The following is a description of a gene set: studied in species Homo sapiens Cholesterol side-chain cleavage enzyme, mitochondrial (CYP11A1) normally catalyses the side-chain cleavage of cholesterol to form pregnenolone. Defects in CYP11A1 can cause Adrenal insufficiency, congenital, with 46,XY sex reversal (AICSR; MIM:613743). This is a rare disorder that can present as acute adrenal insufficiency in infancy with elevated ACTH and plasma renin activity and low or absent adrenal steroids. The severest phenotype is loss-of-function mutations associated with prematurity, complete under-androgenisation and severe, early-onset adrenal failure. Reactome Pathway: Defective CYP11A1 causes AICSR part of: Metabolic disorders of biological oxidation enzymes, and this is the list of marker genes: FDX1, CYP11A1, FDX2, FDXR